Given this list of marker genes PCNT, ORC1, TBCE, MGAT2 (alpha-1,6-mannosyl-glycoprotein 2-beta-N-acetylglucosaminyltransferase), PIGU, HARS1, FDFT1, CDT1, COL1A2, PIGT, ERCC1, NFIX, COL1A1, TOMM7, PPP3CA, HNRNPH1, RSPRY1, GLE1, PDGFRB, FAM111A, BRF1, GMNN, MUSK, POLR3A, B3GALT6, TMEM38B, CDC6, CDC45, PIK3R1, ATP6V0A2, VAC14, ORC6, SCN4A, KCNJ2, CUL7, CCDC134, SCARF2, ORC4, SON, ITCH, NSMCE2, FIG4, RAB3GAP2, OBSL1, MAFB (MAF bZIP transcription factor B), LARP7, P3H1, FBXO11, CCDC8, here is a description of the gene set: species: Homo sapiens Human Gene Set: HP_SLENDER_LONG_BONE Reduced diameter of a long bone. Slender long bone